Given this list of marker genes EREG, PTPRR, MAPK3, MAP2K1, NRG1, PTK6, AREG, ERBB3, MAP2K2, ERBB2, STUB1, ERBB4, BTC, HBEGF, SRC, TGFA, EGFR, MAPK1, MYOC, RAF1, CUL5, CPNE3, EGF (NCBI Gene Id 1950), here is a description of the gene set: The series of molecular signals initiated by binding of a ligand to the tyrosine kinase receptor ERBB2 on the surface of a cell. The pathway ends with regulation of a downstream cellular process, e.g. transcription. ERBB2 receptors are themselves unable to bind to ligands, but act as a signal-amplifying tyrosine kinase within a heterodimeric pair. Human Gene Set: GOBP_ERBB2_SIGNALING_PATHWAY species: Homo sapiens